Given this list of marker genes Rab3a, Wasl, Anxa2, Sh3gl2, Fasl, Asap1, Sytl4, Atp8b1, Dnm2, S100a10, Gsn, Xrcc4, Casp7, Myh9, Sh3glb1 (SH3-domain GRB2-like B1 (endophilin)), Atp10a, here is a description of the gene set: species: Mus musculus Mouse Gene Set: GOBP_REGULATION_OF_PLASMA_MEMBRANE_ORGANIZATION Any process that modulates the frequency, rate or extent of plasma membrane organization.